The following is a description of a gene set: Aflatoxin B1 metabolism species: Mus musculus Mouse Gene Set: WP_AFLATOXIN_B1_METABOLISM, and this is the list of marker genes: Gstm1, Cyp1a2, Ephx1, Akr7a5, Gstt1